Given this list of marker genes KDM5D, TREX1, UNC93B1, ICAM1, WAS, RFTN1, here is a description of the gene set: studied in species Homo sapiens The process in which a T cell expresses antigen (peptide or lipid) on its cell surface in association with an MHC protein complex. Human Gene Set: GOBP_T_CELL_ANTIGEN_PROCESSING_AND_PRESENTATION